The following is a description of a gene set: Human Gene Set: HP_PROXIMAL_AMYOTROPHY Amyotrophy (muscular atrophy) affecting the proximal musculature. Proximal amyotrophy studied in species Homo sapiens, and this is the list of marker genes: VAPB, SPTLC1, TFG, CDH23, MORC2, ADSS1, GFPT1, PEX6, KDM1A, TNNT1, NAA60, ARMC5, POMT2, SGCB, REEP1, SYNE2, TNXB, SGCD (sarcoglycan delta), SLC12A6, INPP5K, RYR1, TRPV4, TP53, FUS, CRPPA, USP8, HNRNPDL, VMA21, DYSF, BRAF, EMD, GNAS, FKRP, TMEM43, MTMR14, SMN1, FKTN, MYH7, SPG11, TCAP, SYNE1, DOK7, DNM2, SMN2, MGME1, USP48, ATRX, ANO5, STIM1, CAPN3 (calpain 3, NCBI Gene Id 825), DYNC1H1, SYT2, FHL1, POMT1, MT-TE, LMNA, NR3C1, TRIM32, NEFL